Given this list of marker genes CTNNB1, TMEM198, ARHGAP28, FAM219A, POLR2M, S1PR1, RASSF3, DIO2, CPQ, NOTCH4, KMT2D, GCOM1, ATP6V1C2, SPCS2, MSL2, BAZ2A, FMO5, SEC14L1, MCM9, KALRN, here is a description of the gene set: studied in species Homo sapiens Genes predicted to be targets of miRBase v22 microRNA hsa-miR-3162-3p in miRDB v6.0 with MirTarget v4 prediction scores > 80 (high confidence targets). from publication Chen Y, Wang X (PMID 31504780) Human Gene Set: MIR3162_3P